Given this list of marker genes INPP4A, INPP1, MTMR7, INPP4B, INPP5K, MINPP1, BPNT1, here is a description of the gene set: Human Gene Set: GOMF_INOSITOL_BISPHOSPHATE_PHOSPHATASE_ACTIVITY Catalysis of the reaction: myo-inositol bisphosphate + H2O = myo-inositol phosphate + phosphate. studied in species Homo sapiens